Given this list of marker genes LYPD3, SYT12, CILP2, MUC13, GSX1, RCAN1, NUBP1, TPR, CCER1 (coiled-coil glutamate rich protein 1), PDGFRA, SRGAP1, HS6ST1, CCL13, LBX2, REM2, ROR2, DNAH8, RNF19A, NIPAL2, TWIST1, ANGPTL6, PLA2G12A, SLFN12L, MARCO, RBM38, BIRC3, C11orf71, IFRD2, RUNX2, KRT77 (NCBI Gene Id 387860), AFM, CLN5, PRSS12, DUSP16, WDR33, TSPAN33, SCAMP1, F3, MTPN, DIP2B, CLASRP (CLK4 associating serine/arginine rich protein), SPTSSB, CHCHD6, GRHPR, ST3GAL5, MED15, TDRD7, DHX32, RPS6KA2, FANCG, DOK5, DNAJB5, NUDT9, FGG, CACNA1S, BRD2, RAB4A, TBC1D8 (NCBI Gene Id 11138), RNF123, NRROS, SLC1A6, CES1, INTS1, ART3, POMT2, OSGIN2, IGSF6, PPP1R1B, LPAR2, CDC25B, TSGA13, DIXDC1, GATA2, KCNMB4, SYNPO, BCL10, FRK, RABEP1, CLEC4E, MAPKAP1, SLC35G6, CHRNA5, ICAM4 (intercellular adhesion molecule 4 (Landsteiner-Wiener blood group)), HSPH1, GADD45GIP1, GLIPR1, IRF8, TTR, MYBBP1A (MYB binding protein 1a), CYP21A1P, CDKN1A, WNT3A, SCNN1B, WNT9A (NCBI Gene Id 92832), KRT1, CTTNBP2NL, GTF2B, TCF20, ADAM23, SRMS, PLPP3, PAH (phenylalanine hydroxylase), SUCO, C16orf89, PDE4B (NCBI Gene Id 5142), FTSJ1, PLA2G10, INSM2, CFLAR, ST3GAL1, SPATA13, LIMA1, RND3 (NCBI Gene Id 390), C9orf50, SPAG6, BRCC3, MEFV, TYMS (thymidylate synthetase), OSBPL1A, ARFGAP3, FST, ICAM1, IGF2R, ZP1, MTMR1, SV2A, ALPK2, NDEL1, KRTAP8-1, PFN3, CALB1, CRIPTO, BTG2, IL10RB, TAF7, GCH1, VCAN, GTF2IRD2, IER5, HOXB9, DBH, PPP2R2B (NCBI Gene Id 56686), IQSEC1, PLSCR1, ADCY8, GRIPAP1, MYO1B, IL17RD, STAT3, CSF3R, ATF3, KLC3, SLC12A1, KIF13A, ZEB2, CD70, TAS1R3, SPRY1, ELP2, NDP, ROBO1, IL23A, B3GNT2, ZNF354A, STAT5A, TAC1, FCER1A, ZC3H3, MAP3K4, HCAR2, ALKBH3, NFIX, FAM53C, RILPL1, TRHR, SLC39A3 (solute carrier family 39 member 3), YTHDC1, VPS37C, SLN, KERA, TMEM175, FRMD6, BRWD1, MAP3K8, SPON1, RALGDS, UNCX, OLR1, TMEM266, LAS1L, FSCN1, CDKAL1, STK40, PALLD, ERRFI1 (ERBB receptor feedback inhibitor 1), HPCA, GPN2, NUDCD1, ARID5A, here is a description of the gene set: from publication Amit I, Garber M, Chevrier N, Leite AP, Donner Y, Eisenhaure T, Guttman M, Grenier JK, Li W, Zuk O, Schubert LA, Birditt B, Shay T, Goren A, Zhang X, Smith Z, Deering R, McDonald RC, Cabili M, Bernstein BE, Rinn JL, Meissner A, Root DE, Hacohen N, Regev A (PMID 19729616) Human Gene Set: GSE17721_CTRL_VS_PAM3CSK4_1H_BMDC_DN Genes down-regulated in comparison of control dendritic cells (DC) at 1 h versus those stimulated with Pam3Csk4 (TLR1/2 agonist) at 1 h. mouse primary BMDCs were stimulated with tlr ligands and gene expression changes were profiled on Affymetrix arrays species: Homo sapiens